Given this list of marker genes H2-M3, Asb10, Ppp2r1b, H4c11, Psmd12, Actr1a, Cdc26, Arel1, H2bc3, Ube2e2, Siglece, Jaml, Glmn, Prkag3, H2ac1, Ube3b, Cd200r2, Pja1, Thop1, H2-M10.1, Clec4g, Tap1, Cul7 (NCBI Gene Id 66515), H2bc22, H2ac4 (NCBI Gene Id 319172), Tuba3b, Pik3cb, Tuba1c, Mrc2, Asb14, Ube2o, H3f3a, Syk, Ikbkb, Asb9 (NCBI Gene Id 69299), Ifitm1, Cd36, Prkn, Ubb, Tmem258, Atg7, Herc3, H2bc13, Icam5, Prkaca, Siglecf, Itgb7, Asb16, H2ac12, Asb17, Cd300ld4, H2bc15, Cd96, H2ac22, Lmo7, H3c2, Psma4, Raet1e, Ubac1, Lck, Cd274 (CD274 antigen), Siah1a, Derl1, Cd300ld5, Ctla4, Icam4 (intercellular adhesion molecule 4, Landsteiner-Wiener blood group), Rnf217, Ppl, Rnf4, Ddost, H2-M2, Fbxo30, Ctsc, Kif26a, Fbxl4, Ube2e1, Sec24b, Klc3, H2ac15, Hecw2, Ctsh, Kctd7, Hcst, C3, Ptpn22, H2ac24, H2-Q7, Socs3, Cd207, Hras, Btnl9, Kif20a, Ube2r2, Tuba1b, Bcap31, Fbxw9, Fbxl8, Klhl13, Lat, Psmb9, Cdk4, Osbpl1a, Trim36, Ap1b1, H2-M10.6, H4c2, Pja2, Itk, Dctn1, Blnk, Ncf2, Trem2, Trem1, Vhl, Cd8b1, Grap2, Ube2k, Cbll1, Psma5, Ptpn6, Btn1a1, Rnf182, Sec31a, Ezh2, Vcp, H2ac19, Cul1, H3c6, Tubal3, Fbxl3, Pilra, Lcp2, H2ac13, Ulbp1, Siglec1, Psmd6, Psmc6, Ctss, Ube2s, Ctsf, Igll1, Ppp3r1, Tuba8, Anapc13, Smurf2, Unkl, H2ac10, Fbxo40, Asb18, Cd80, Psme1, Dync1li2, Lag3, Ap2s1, Cdc42 (cell division cycle 42), Psmc5, Itgb2, Mib2, Psmb10, Ccnd1, Smurf1, H2ac8, Lnx1, Sel1l, Rnf126, Rnf19a, Cblb (Casitas B-lineage lymphoma b), H3c4, Pik3ap1, H2bc8, H2-Q10, Ifitm2, Dapp1, Cd209a, Uba7, Cdc23, Malt1, Cd3e, Fbxl13, Calm1, Anapc2, Ube2d1 (NCBI Gene Id 216080), Kif2b, Ap2m1, Cd74, H4c18, Kif3c, Psmc3, Lonrf1, Spsb2, Asb11, Fbxl14, H2bc7, Rab7, Klhl41, Nfkb1, Nfkbib, Prkacb, Nfkbia, Treml2, Fbxl7, Cd79b, Cyba, Cd3d, H2bc11, Vav1, Ifitm3, Socs1, Stt3b, H4c4 (NCBI Gene Id 319156), Psmc4, Rnf111, Fzr1, Ctsd, Tnfrsf14, Ube2v1, Arih2, Pdcd1 (programmed cell death 1), Rnf7, Ap1m1, Ccnf, Icos, Gan, Psma3, Crtam, Icosl, Tubb6, Fbxo9, Erap1, Siglecg, Cd28, Klhl5, Psmc1 (protease (prosome, macropain) 26S subunit, ATPase 1), Hectd3, Ppp2r5d, Yes1, Vamp8, H3c13, Rasgrp3, H4c17, Kbtbd8, Fbxw4, Psmc2, Psmb4, Anapc10, Cd3g, H2bc27, Pag1, Fbxo10, Ufl1, Fbxl21, Ncf1, Plcg2, Xdh, H3c8, Nectin2, H4c3, Rnf144b, Psmb5, Psmb6, Klrk1, H3c15, Lrr1, H2ac11, Fbxl15, Dcaf1, Fyn, H2ac20, Itgb5, Ube2e3, Tpp2 (NCBI Gene Id 22019), H3c3, H3c7, H2-M9, Dad1, Fbxo17, Ost4, Btbd6, Them4, Slamf7, Rbbp4 (retinoblastoma binding protein 4, chromatin remodeling factor), Sec24d, Ap1s1, Hectd2, Fbxl19, H2bc12, H4c6, Stt3a, Anapc7 (anaphase promoting complex subunit 7), Klhl11, H2ac6, Trim50, Ube2w, H2bc9, Cd226, Fbxo27, H2bc1, Itga4, Pik3r2, Cenpe, Fbxo31, Psme2, Map3k14, Wsb1, Stim1, Tubb2b, Psmd7, Psmd13, B3gnt3, Uba1, H3c10, Fkbp1a, Pianp, Tuba1a, Cd300lb, Actr10, Traip, H4c1, Trpc1, Map3k8, Cd300ld, Btbd1, Kbtbd13, Tubb4a, Det1, Csnk2b, Derl3, Lgmn, H2-Ob, H3c11, Nfkbie, Sec24a, Psmd1, Kctd6, Ap2a1, Rasgrp1, Ppp2r5b, B2m, Dctn6, Rictor, Prkag1, Spop, Rnf123, H2ac23, Kif2c, Ube3d (NCBI Gene Id 70348), Tab2, Arf1, Col17a1, Ap2b1, Rnf6, Fbxl16, Dnm2, Pdcd1lg2, Dynll1, H4c12, Trim32, Ppp2r5a, Calr, Rchy1, Asb12 (NCBI Gene Id 70392), Psma7, Kif5b, Pak3, Trim11, Ptprc, Ube2n, Rps27a, Pdpk1, Icam2, Ifi30, Psma2, H2-Oa, Trat1, Itgal, Pik3r5, Cd300ld3, Psma6, Tusc3, Fbxl5, H2ax, Asb8, Psmb7, Ube2g1, Asb5, Sptbn2 (spectrin beta, non-erythrocytic 2), Cd79a, Grb2, Lrsam1, Treml1, Btn2a2, Trim39, Tap2, Racgap1, Ube3c, H3c1, Fbxo32, Psmb8, Tuba4a (NCBI Gene Id 22145), Cd81, Cd40lg, Rnf213, Rbbp7, Cd300e, Ube2c, Klc4, H2-M10.2, Klrb1a, H4c8, Cd19 (CD19 antigen), Csk, Rela, H4c14, Psma1, H4c9, Uba5 (NCBI Gene Id 66663), H2ac7, Ap1s3, H2az2, Erlec1, Trim9, Kifap3, Dtx3l, Trim69, Cdc34, Tubb4b, here is a description of the gene set: Reactome Pathway: Adaptive Immune System electronically inferred by orthology from the curated human pathway part of: Immune System studied in species Mus musculus This event has been computationally inferred from an event that has been demonstrated in another species.<p>The inference is based on the homology mapping from PANTHER. Briefly, reactions for which all involved PhysicalEntities (in input, output and catalyst) have a mapped orthologue/paralogue (for complexes at least 75% of components must have a mapping) are inferred to the other species.